The following is a description of a gene set: Any process that results in a change in state or activity of a cell or an organism (in terms of movement, secretion, enzyme production, gene expression, etc.) as a result of a corticosteroid hormone stimulus. A corticosteroid is a steroid hormone that is produced in the adrenal cortex. Corticosteroids are involved in a wide range of physiologic systems such as stress response, immune response and regulation of inflammation, carbohydrate metabolism, protein catabolism, blood electrolyte levels, and behavior. They include glucocorticoids and mineralocorticoids. species: Mus musculus Mouse Gene Set: GOBP_RESPONSE_TO_CORTICOSTEROID, and this is the list of marker genes: Nr3c1, Epo, Cybb, Etnppl, Pdcd7, Casp3, Hdac6, Bmp4, Zfp747l1, Abcc1, Edn1, Gba1, Scnn1b, Cpn1, Th, Scgb1a1, Acsbg1, Fosl2, Ube2l3, Fosb, Gpr83, Aanat, Cad, Zfp36l1, Atp5f1a, Pcna, Il10, Abca3, Pappa, Ifnb1, Sgk1, Pik3ca, Bckdhb, Ddit4, Rpl27, Nefl, Adam9, Agl, Zfp764, Gdnf (NCBI Gene Id 14573), Pck1, Trim63, Rps6kb1, Ep300, Ugt1a6a, Adm, Axin2, Avpr1a, Agtr1a, Cyp1b1, Ugt1a1, Hnrnpu, Tat, Il6, Pdx1, Bcl2, Fech, Csn1s1, Sstr5, Gjb2, Ucn3, Serpinf1, Ucp3, Abcb1a, Src, Zfp747, Fos (FBJ osteosarcoma oncogene), Ace, Gsk3a, Tnf, Got1, Pik3r1, Akr1c18, Gkn2, Zfp36l2, Htr7, A2m, Aqp1, Ghsr, Ucn, Fkrp, mt-Nd3, Igfbp2, Hnmt, Ccl2, Myod1, Zfp36, Fosl1, Gper1, Nr3c2, Agtr2, Pck2, Calcr, Eif4e, Ptpru, Ptgds, Slit3, Slc12a3, Slco1b2, Pf4 (platelet factor 4), Sdc1, Sstr2, Sult1a1, Zfp764l1, Map2k1, Eif4ebp1, Maob, Star, Adipoq, Sstr3, Trh, Lcat, Mstn, Aldh3a1, Scnn1a, Sox30, Cldn1, Anxa3, Cdo1, Mettl21c, Bmi1, Alad, Card9, Agxt, Il17a, Tbx2, Smyd3, Glb1, Alpl, Ugt1a6b, Gad2, Il1rn, Fam107a, Jak2, Hdac8, Ptgs2, Inhba, Tgfb1, Rest, Foxo3, Cxcl2, Hsd11b2, Agtr1b, Cdkn1a, Npas4, Hmgb1, Ctsl, Egfr, Rxra (retinoid X receptor alpha), Mir155, Hmgcs2, Adcyap1, Htr1b, Gsk3b, Pcsk1, Stc1, Ghrhr, Stk39, Scnn1g, Oxt, Tyms, Foxo1, Fas, Mir21a (NCBI Gene Id 387140), Comt, Por, Casp9, Areg, Ptafr, Bche, Pfkfb1, Crh, Asns, Anxa1, Fbxo32, Bmp6, Klf9, Ucp2, Aifm1, Sstr4 (NCBI Gene Id 20608), Cps1, Gstp1, Ass1